The following is a description of a gene set: from publication Travaglini KJ, Nabhan AN, Penland L, Sinha R, Gillich A, Sit RV, Chang S, Conley SD, Mori Y, Seita J, Berry GJ, Shrager JB, Metzger RJ, Kuo CS, Neff N, Weissman IL, Quake SR, Krasnow MA (PMID 33208946) species: Homo sapiens Human Gene Set: TRAVAGLINI_LUNG_AIRWAY_SMOOTH_MUSCLE_CELL, and this is the list of marker genes: RAB20, IGFBP7, JPH2, TMEM38B, LDB3, ANGPT2, CAV1, TBC1D1, HSPB7, CPED1, SOD3, RPL27, RPL21, CNN1, ACTN1 (NCBI Gene Id 87), RPS27, SPEG, CD151, MYOCD, NDUFB2, TSPAN2, ANAPC16, RAMP1, SLIRP, PDLIM5, MAP1B, UQCRB, RPS14, H2AJ, IRAG1, TAGLN, NTF3, CRYAB, EFHD1, RPL37A, RPL31, C12orf75, PTMA, TGM2, KCNMB1, WFDC1, RPL14, NIBAN1 (niban apoptosis regulator 1), TNNT2, MEF2C, BCAM, RASGRP2, TINAGL1, MYLK, PFN1, RPS27A, NDUFB1, PPP1R12A, IGFBP5, RPS6, UQCRQ, EDNRB, FLNA, MYL9, UBL5, RPL23A, RPL34, PLN, TM4SF1, MYOZ1, CASQ2, ENTPD1, ID4, NEXN, RPLP1, MRPL33, RASSF3, MOB2, LPP, SH3BGRL, NDUFB4, TPM2, RPL5 (ribosomal protein L5), ALDOC, ISYNA1, LIMS2, TBX2-AS1, CHURC1, HSPB1, HCFC1R1, CRIP2, HES4, CAV2, CAMK2G, HEY2, CCN3, PLAC9, GPRC5C, CCN5, MGST3, MYL6, NRGN, SEPTIN7, KCNA5, DES, RPL41, RPL27A, MICAL1, PPP1R14A, SERPINI1 (NCBI Gene Id 5274), CSRP2, CDH13, SYNPO2, EPAS1, CD9, CSRP1, NOL3, JAK2, MYH11, ACTA2, MZT2B, RERGL, SORBS2, EZR, KANK2, SNCG, NDUFB7, RPL38, WDR1, ATP1A2, TPM1, UNC45B, MCAM, MSRB3 (NCBI Gene Id 253827), ITGA7, AKAP1, LMOD1, RPS16, RPL18, ANTXR1, NDUFA4, ITIH3, MGLL, ESAM, NET1, MAP3K7CL, COX7C, RPL10A, KRT18, SORBS1, RPS21, COX6A1, NTN4, KCNAB1 (potassium voltage-gated channel subfamily A regulatory beta subunit 1), ROCK1, TLN1, HACD1, TGFB1I1, FOXS1, RPL23, CALM2, THSD4, SLMAP, COX7A1, ACTG2, CAP2, NTRK3, RCAN2, PPP1R12B, DSTN, SLC38A1